Given this list of marker genes MAP2, GSK3A, RAB3IP, KCNB1, PPP5C, SLC1A1, GRIA1, GIGYF2, here is a description of the gene set: species: Homo sapiens The dendrite of the dendritic tree that is closest to the neuronal cell body (the soma). Human Gene Set: GOCC_PROXIMAL_DENDRITE